The following is a description of a gene set: Human Gene Set: MIR4436B_5P Genes predicted to be targets of miRBase v22 microRNA hsa-miR-4436b-5p in miRDB v6.0 with MirTarget v4 prediction scores > 80 (high confidence targets). studied in species Homo sapiens from publication Chen Y, Wang X (PMID 31504780), and this is the list of marker genes: PPIP5K2, HTR2C, KIF5C, CEP350, CDC14A, UBE2D2, DAZ2, SEC22C, PDCD4, SQLE, CLOCK, CHD4, GPATCH1, CTPS2, PDK2, NKX2-4, IRX2, ZNF548, P2RY10, IAPP, STAG2, HSPA8, DDX60, ZNF605, PHF14, SRSF8, SHC4 (SHC adaptor protein 4), RBM15, HECTD2, YWHAZ, RAD51AP1, TBC1D15, NAV3, ZNF268, ZFP1, KATNBL1, BMAL1 (basic helix-loop-helix ARNT like 1), TVP23B, TVP23C, TBK1 (NCBI Gene Id 29110), RAB8B, OSTM1, TTC39B, HILPDA, RAPGEF2, REPS2, ZNF451 (NCBI Gene Id 80822), ATXN1, ZFR, HNRNPH1, SVIP, CSTPP1, LMCD1, GALR1, SOWAHD, SESN3, KIRREL1, PARP14, AFG1L, ACTR2, PPARGC1B, CXCL8, SCN1A, DYNC1LI1, DNAJC22, FAM111B, AASDHPPT, ZMYM2, ATP6V1A, ETF1, ITM2C, TRIM36, KIF3B, ANKRD26, PPM1A, CAB39, CDYL2, SAMD12, CCNY, PNRC2, ASCC1, CSNK1A1, ILF3, BICC1, CANT1, HAND2, NAA30, ZNF37A, CAMSAP1, TPST2, ZMAT1, ZNF616, CCDC144A, DTWD2, TTC39C, SGIP1, FKBP4, WDR47, ENOX1 (ecto-NOX disulfide-thiol exchanger 1), CADM2, GYS2, CDK15, AMMECR1, CACNB2, OGFOD1, RBMX, LINC02901, MCM10, FRMD3, GUCY1A2, BCAP29, SAMD4B, RBM26, AEBP2, CAPN7, FOCAD, NPHS1, USP13, EIF3J, PHIP, MCTS1, TARDBP, FAM53C, LTA4H, GAS7, TMEM50B, ZNF618, GRK5, KLHL1, TBCEL, PTP4A1, MAP2K1, CCN4, TMEM170B, AKTIP, KCMF1, PARP4, TMED4, WDR33, MPPE1, USP38